The following is a description of a gene set: Human Gene Set: GOMF_O_METHYLTRANSFERASE_ACTIVITY studied in species Homo sapiens Catalysis of the transfer of a methyl group to the oxygen atom of an acceptor molecule., and this is the list of marker genes: COQ3 (coenzyme Q3, methyltransferase), COMT, FTSJ3, PCMT1, FBL, HENMT1, CMTR2, MEPCE, ASMTL, COMTD1, ARMT1, PCMTD2, FBLL1 (fibrillarin like 1), FTSJ1, ASMT, PCMTD1, CMTR1, ICMT, BCDIN3D, TRMT13, LCMT1, MRM3, MRM1, MRM2